Given this list of marker genes Hspb1, Prkcg, Prkcd, Pkn2, Prkci, Prkd3 (protein kinase D3), Prkd2, Prkd1, Prkcz, Prkca, Prkch, Pkn1, Prkcb (NCBI Gene Id 319718), Prkcq (protein kinase C, theta), Pkn3, Prkce, Smg1, here is a description of the gene set: studied in species Mus musculus Catalysis of the reaction: ATP + a protein = ADP + a phosphoprotein. This reaction requires diacylglycerol. Mouse Gene Set: GOMF_DIACYLGLYCEROL_DEPENDENT_SERINE_THREONINE_KINASE_ACTIVITY